Given this list of marker genes Mfap5, Itgb8, Bmp4, Emilin2, Mfap2, Mfap4, Ltbp2, Fbln5, Tgfb1, Bmp10, Itgb5, Vtn, Ltbp3, Bmp7, here is a description of the gene set: electronically inferred by orthology from the curated human pathway part of: Elastic fibre formation Reactome Pathway: Molecules associated with elastic fibres This event has been computationally inferred from an event that has been demonstrated in another species.<p>The inference is based on the homology mapping from PANTHER. Briefly, reactions for which all involved PhysicalEntities (in input, output and catalyst) have a mapped orthologue/paralogue (for complexes at least 75% of components must have a mapping) are inferred to the other species. studied in species Mus musculus